The following is a description of a gene set: species: Mus musculus Mouse Gene Set: GOMF_UBIQUITIN_PROTEIN_TRANSFERASE_ACTIVATOR_ACTIVITY Binds to and increases the activity of a ubiquitin-protein transferase., and this is the list of marker genes: Rbck1, Cdkn1b, Cbx8, Pin1rt1, Cdc20b, Bmi1, Pcgf2 (NCBI Gene Id 22658), Cdc20, Ube2l3, Entrep1, Btrc, Ring1, Pten, Pin1 (NCBI Gene Id 67670), Pex12, Fbxw7, Ube2n, Fzr1